The following is a description of a gene set: species: Homo sapiens The epoxidation of arachidonate by cytochrome P450s (CYPs) results in the formation of unique bioactive lipid mediators termed epoxyeicosatrienoates (EETs). Each double bond has been shown to be susceptible to oxidation, resulting in 5,6-EET, 8,9-EET, 11,12-EET, and 14,15-EET. The majority of the EET biological activities are diminished by the hydrolysis to the corresponding dihydroxyeicosatrienoates (DHET). Reactome Pathway: Synthesis of epoxy (EET) and dihydroxyeicosatrienoic acids (DHET) part of: Arachidonate metabolism, and this is the list of marker genes: CYP2C19, CYP1A1, CYP1A2, EPHX2, CYP1B1, CYP2C9, CYP2C8, CYP2J2